The following is a description of a gene set: studied in species Mus musculus Mouse Gene Set: REACTOME_RELEASE_OF_APOPTOTIC_FACTORS_FROM_THE_MITOCHONDRIA Release of apoptotic factors from the mitochondria, and this is the list of marker genes: Septin4, Cycs, Gsdme, Bak1, Diablo, Gm10053, Bax, Gsdmd